Given this list of marker genes GFM2, ZFTA, GLA, CARD8, DLD, NDUFA11, GHSR, GFAP, SPP1, HELLPAR, FBLN5, COL1A1, DOLK, IVD, BOLA3, CPS1, GAN (gigaxonin), NDUFAF8, KIT, TOM1, UQCC2, BRAF, MRPS7, PIGY, TNF, CDK8, NFIX, NDUFAF3, POLG, CLMP, HMGCL, ALG8, ESR1, NARS2, PMM2, HSD3B2, TNFRSF1A, APC, CTNNB1, MT-CYB, MT-ND5, PHKA2, ALX4, NDUFB8 (NADH:ubiquinone oxidoreductase subunit B8), GAS1, ITGB4, ASS1, SCNN1G, ASXL1, SLC22A5, NODAL, DGUOK (NCBI Gene Id 1716), EDN3, MT-TQ, PDCD10, ACAT1, SMC1A, MT-ND1, CUBN, AAAS (aladin WD repeat nucleoporin), MMUT, CYP11B2, MT-TS2, AMN, NSD1, NDUFS8, ATP1A3, COL4A6, NDUFB11, EGFR, PERCC1 (NCBI Gene Id 105371045), CLCNKA, CDK13, NOTCH2NLC, PGM1, HNF4A, SUCLG1, ATRX, GRB10, GBA1, NDUFAF2, GK, GLI2, YARS1, SLC22A12, SI, PIK3CA, AIP, POGZ, CTRC, GALT, CFH, NDUFS1, FARSB, MARS1, LAMA3, MTHFD1, NDUFA2, GALE, MVK, NDUFS7, CD55, ASPA, NDUFA1, NUBPL, CLDN16, PHGDH, LBX1, PTCH1, RYR1, CPT2 (NCBI Gene Id 1376), GALC, NR0B1, ALPL, CA5A, TXNRD2, HLCS, SEC61A1, AGR2, NDUFS3, ACADM, PSAP (prosaposin), SLC1A3, ALAD, STAR, KARS1, TYMP, NDUFV2, RARS1, MT-ATP6, ATP1A2, TWNK, SMPD1, PPOX, KYNU, ABCC8, SAT1, ALG9, NDUFAF1, MTRR, ZEB2 (zinc finger E-box binding homeobox 2), NDUFB3, MET, SYT1, STIL, MLYCD, FBXL4, FGFR1, SLC2A9, MT-CO2, MMACHC, MT-ND6, PHKG2, SLC7A7, HIKESHI, HS3ST6, HPRT1, ACSL5, MPV17, UQCRC2, NDUFS2, PCCB, STAT4, AASS, TUBB2B, LPL, TIMMDC1, CRIPTO, TEFM (transcription elongation factor, mitochondrial), CCM2, SCNN1A, COL5A2, NDUFA6, MCCC2, KRIT1 (NCBI Gene Id 9602), NDUFV1, DYRK1A, SEMA3C, NBAS, AVP, OPLAH, STAG2, FOCAD, MRAP, CTNS, RANBP2, NSUN2, SHANK3, BSND, ATP7B, MT-TK, MT-TF, LAMB3, NLRC4, LIPA, COL4A5, SPTBN1, SIX3, ACSF3, ALDOB, CDKN1B, COQ2, ETFA, ABCD1, SAR1B, MRPL39, NEUROG3, NUP214, ALDH18A1, HLA-DQA1, CLCNKB, SEMA3D (semaphorin 3D), LAMC2, SLC5A1, DBH, MT-CO1 (NCBI Gene Id 4512), FOXH1, LIG3 (DNA ligase 3), NAGS, FOXRED1, AIMP1 (aminoacyl tRNA synthetase complex interacting multifunctional protein 1), SPINK1, TUBB3, NDUFS4, TP53, LRPPRC, MTTP, NR3C2, KIF21A, NRTN, SERPING1, NDUFB10, HLA-DQB1, COL5A1, SLC12A1, RNH1, ERBB3, CDON, SCN2A, CDC42BPB, ACY1, PPM1D, PHKB, TMEM126B, KCNJ11, BCKDHA, GAMT (guanidinoacetate N-methyltransferase), ETFDH, UQCRH, PLEC, SLC19A3, COL25A1, MT-ND2, ATP7A, F12, GMPPA, STX3, DLL1, NDUFAF4, NDUFAF5, TRAPPC11, MT-TL1, SSR4, GPD1, TUBA1A, PHOX2A, D2HGDH, MT-TW, DHCR7 (7-dehydrocholesterol reductase), SUGCT, CDKN1A, FGF13, CYP24A1, PRDX1, MSX2, CPOX, FBXO11, FGF8, LIG4, GDNF, SAA1, ELN, CDKN2C, MT-ND4, ABCC6, EDNRA, IRAK1, PCCA, UNC45A, SLC5A6, BTD, PYCR2, PKHD1, TCN2, MCCC1, OXCT1, HMGCS2, CYP11A1, RRM1, MEN1, SLC37A4, RRM2B, COA8, SLC12A3, SLC25A13, FOXP3, ACTG2, ADNP, RET, TGIF1, HMBS, ALG11, UFC1, ALG3, ERBB2, HNRNPK, KMT2E, ATP6V0A4, EDNRB, KCNJ1, MPI, MEFV, CDKN2B, DISP1, FAH, TRMU, SYK, MTR, SCNN1B, TIMM22, CAV1, MT-CO3, CACNA1A, ZFX (zinc finger protein X-linked), ASXL3, NAXD, ACADVL, MMAB, SREBF1, ZIC2, ARG1, TREH, SHH, CYC1, SLC25A15, OTC (NCBI Gene Id 5009), NDUFS6, SMO, NAA10, ST3GAL5, PNPT1 (NCBI Gene Id 87178), MT-TH, ETFB, ECE1, MT-TC, PLCH1, EPCAM, TTR, AQP2, CDH23, RECQL4 (RecQ like helicase 4), ACAD8, CD46, MMAA, FLNA, MT-ND3, MT-TV, NEXMIF, MED12, SLC6A8, MC2R, AVPR2, DGAT1, FBP1, ANAPC1, ANO1, ELP1, CFI, NNT, HADH, ASL, ENPP1 (NCBI Gene Id 5167), SUOX, NDUFB9, STK11, HIBCH, here is a description of the gene set: Vomiting Forceful ejection of the contents of the stomach through the mouth by means of a series of involuntary spasmic contractions. Human Gene Set: HP_VOMITING species: Homo sapiens